The following is a description of a gene set: Genes within the smallest region of consistend deletion (SRD) within 1p36.3 area across a large collection of neuroblastoma cell lines and biopsy samples. studied in species Homo sapiens from publication White PS, Thompson PM, Gotoh T, Okawa ER, Igarashi J, Kok M, Winter C, Gregory SG, Hogarty MD, Maris JM, Brodeur GM (PMID 15829979) Substantial genomic and functional evidence from primary tumors and cell lines indicates that a consistent region of distal chromosome 1p is deleted in a sizable proportion of human neuroblastomas, suggesting that this region contains one or more tumor suppressor genes. To determine systematically and precisely the location and extent of 1p deletion in neuroblastomas, we performed allelic loss studies of 737 primary neuroblastomas and genotype analysis of 46 neuroblastoma cell lines. Together, the results defined a single region within 1p36.3 that was consistently deleted in 25% of tumors and 87% of cell lines. Two neuroblastoma patients had constitutional deletions of distal 1p36 that overlapped the tumor-defined region. The tumor- and constitutionally-derived deletions together defined a smallest region of consistent deletion (SRD) between D1S2795 and The 1p36.3 SRD was deleted in all but one of the 184 tumors with 1p deletion. Physical mapping and DNA sequencing determined that the SRD minimally spans an estimated 729 kb. Genomic content and sequence analysis of the SRD identified 15 characterized, nine uncharacterized, and six predicted genes in the region. The RNA expression profiles of 21 of the genes were investigated in a variety of normal tissues. The SHREW1 and KCNAB2 genes both had tissue-restricted expression patterns, including expression in the nervous system. In addition, a novel gene (CHD5) with strong homology to proteins involved in chromatin remodeling was expressed mainly in neural tissues. Together, these results suggest that one or more genes involved in neuroblastoma tumorigenesis or tumor progression are likely contained within this region. Human Gene Set: WHITE_NEUROBLASTOMA_WITH_1P36.3_DELETION, and this is the list of marker genes: KCNAB2, ACOT7, CAMTA1, RNF207, DNAJC11, CHD5, PLEKHG5, GPR153, ZBTB48, RPL22, NOL9, AJAP1, TAS1R1, KLHL21 (NCBI Gene Id 9903), ESPN, HES2, TNFRSF25, ICMT, PHF13, ICMT-DT